Given this list of marker genes Prickle1, Selplg, Pstpip1, Icam2, Dnm2, Pip5k1c, Pip5k1b, Ezr, Scimp, Msn, Spn, Flot1, Myh9, Flot2, Bst1, here is a description of the gene set: Mouse Gene Set: GOCC_CELL_TRAILING_EDGE studied in species Mus musculus The area of a motile cell opposite to the direction of movement.